Given this list of marker genes Acot7, Dbi, Scp2, Pnpla3, Hnf4a (hepatic nuclear factor 4, alpha), here is a description of the gene set: species: Mus musculus Mouse Gene Set: GOMF_LONG_CHAIN_FATTY_ACYL_COA_BINDING Binding to a long-chain fatty acyl-CoA, any derivative of coenzyme A in which the sulfhydryl group is in a thioester linkage with a long-chain fatty-acyl group. A long-chain fatty acid has an aliphatic tail containing 13 to 22 carbons.